The following is a description of a gene set: part of: HDR through Homologous Recombination (HRR) or Single Strand Annealing (SSA) electronically inferred by orthology from the curated human pathway Reactome Pathway: Processing of DNA double-strand break ends studied in species Mus musculus This event has been computationally inferred from an event that has been demonstrated in another species.<p>The inference is based on the homology mapping from PANTHER. Briefly, reactions for which all involved PhysicalEntities (in input, output and catalyst) have a mapped orthologue/paralogue (for complexes at least 75% of components must have a mapping) are inferred to the other species., and this is the list of marker genes: Dna2, Babam1, Brca1, Nbn, Rfc3, Ubb, Rad1, H4c18, Ppp4c, Wrn (NCBI Gene Id 22427), Trp53bp1, Rad9a, H2ax, Top3a, Ube2n, Ccna1 (cyclin A1), H4c1, H4c8, H4c6, H2bc12, H2bc9, H4c14, Rbbp8, Ppp4r2, Rpa1, H4c11, Mdc1, H4c4, H2bc13, Rps27a, Hus1, H4c3, H2bc8, Rnf168, Brcc3, Bard1, H2bc3, Pias4, H2bc15, Mre11a, Blm, Rnf4, H2bc11, Kat5, H4c12, H2bc27, H4c17, H2bc1, H4c9, H2bc22, H4c2, H2bc7